Given this list of marker genes KIF19, ARCN1, TMED7, KIF18B, COPB1, SURF4, COPA, KIFC2, TUBA3E, TUBA1A, AGPAT3, KLC1, DYNC1H1, KIF9, NAPB, TUBB2B, KLC4, COPG1 (NCBI Gene Id 51137), KIF27, KIF28P, KIF4A, KIF3B, TUBA4A, GALNT2, TUBB4B, KDELR1, TUBB2A, KIF3C, TUBA1B, TUBB1, RAB6B, KIF2A (kinesin family member 2A), GALNT1, COPZ1, BNIP1, USE1 (unconventional SNARE in the ER 1), KIF1B, DCTN2, KIF2C, TMED9, KIF20B, ZW10, TUBA3D, ARF5, PAFAH1B3, NSF, KIF13B, PAFAH1B1, KIF1A, DCTN1 (NCBI Gene Id 82109), KIF5C, DYNLL2, CAPZA3, DYNC1LI1, COPG2, ACTR1A, KIF3A, TUBA4B, RAB1A, KIF2B, DYNC1LI2, RACGAP1, DYNLL1, COPB2, KIF21A, KIF11, KIF12, DYNC1I1, KIF5B, COPE, KIF26B, RAB3GAP2, KIFC1, CENPE (NCBI Gene Id 1062), SEC22B, GBF1, BICD1, TUBB4A, TUBA1C, STX18, TUBB8, KIF6, ACTR10, TUBA3C, KIFAP3, TUBB6, RINT1, PLA2G6, KIF18A, TUBA8, ARF3, KDELR2, KIF23, KLC3, ARF1, NAPG, KIF25, KIF15, TMED10, KIF1C, KIF4B, KIF26A (NCBI Gene Id 26153), PAFAH1B2, DCTN3, KLC2, TMED3, PLA2G4A, DCTN6, RAB1B, KIF16B, COPZ2, DYNC1I2, ARF4, ARFGAP1, NBAS, TMED2, KDELR3, CAPZB, RAB18, DCTN4, CAPZA1, RAB3GAP1, KIF20A, ARFGAP2, TUBAL3, TUBB8B, BICD2, RAB6A, KIF5A, DCTN5, ARFGAP3, NAPA, TUBB3, CAPZA2, KIF21B, KIF22, here is a description of the gene set: Reactome Pathway: Golgi-to-ER retrograde transport studied in species Homo sapiens part of: Intra-Golgi and retrograde Golgi-to-ER traffic Retrograde traffic from the cis-Golgi to the ERGIC or the ER occurs through either COPI-coated vesicles or through a less well characterized RAB6-dependent route that makes use of tubular carriers. The balance between these two pathways may be influenced cargo type and concentration and membrane composition, though the details remain to be worked out.